Given this list of marker genes MTF2, MIR4674, CELF2, LNC-LBCS, NOTCH1, ENSG00000214650, here is a description of the gene set: studied in species Homo sapiens Genes containing one or more binding sites for (SOX15) in their promoter regions (TSS -1000,+100 bp) as identified by GTRD version 20.06 ChIP-seq harmonization. from publication Yevshin I, Sharipov R, Kolmykov S, Kondrakhin Y, Kolpakov F (PMID 30445619) Human Gene Set: SOX15_TARGET_GENES